Given this list of marker genes LSM4, APCDD1, SYT17, MYD88, ZBP1, WWOX, EDN1, RANBP3, SLAMF7, HSPB8 (NCBI Gene Id 8097), LY6G6D, SEC24B, EP400 (E1A binding protein p400), H1-4, EREG, TBC1D10B, SLC44A1, RMDN3, IFIT3, NDST2, PTMS, SLK, LPAR1, ARF5, DNAJC13, YTHDF1, PRDM1, TMEM192, UTRN, ACTB, CNIH2, KAT2B, PKIG, DNMT3A, TMBIM4, PDE1B, KRT85, HSPA2, TSPAN5, CASP4, MYBPH, SLC1A2, SPECC1 (NCBI Gene Id 92521), CUEDC1, BBS2, HTRA2, RNF214, UAP1, TAB3 (NCBI Gene Id 257397), MT4, SSR3, CAPN5, NIPAL2, CTNNA1 (catenin alpha 1), IL6, PRPF38A, KATNA1, GAS7, DDAH2, MAP4, AKT2, MAEA, GNG11, ARPP19, MRPS12, CABYR, PI4K2A, GABRA2, PARP14, STX1B, CA2, TXNDC17 (NCBI Gene Id 84817), UPP1, RCN2, PNRC1, NTS, CD180, XDH, TSPAN13, SLCO3A1, RIN1, MXI1, ITPK1, FKBPL, TMCO3, TPX2, SEC63, AZI2, LBH, DUSP16, RAB8B, APBB1IP, TIMELESS, PDGFRB, MYCN, TOMM70, CYP17A1, PKNOX2, IDNK, PTCRA, TUT7, KEAP1, TNXB, DAZ2, MAPK6, LONP2, LANCL2, WARS1, PHF21A, NCOA5 (nuclear receptor coactivator 5), SP6, HCN2, NDRG2, CASK, IFT81, PLEKHA2, IFI35, SHD, USP47, BOC, ABI3BP, ARHGAP23, EPHA6, WIPI1, SPHK2, PPM1B, IDH2, MRPS6, ATG4D, CCNE1, ZBTB11-AS1, CD300LF, BABAM1, ALDH1A2, NYNRIN, UFM1, NHERF1, ASB6, PI4K2B, NUDT19, BRAF, ARHGAP35, RLBP1, SKIL, CRIM1, SAT1, MAPK13, DEK, CISH, IGF2, SUV39H1, SLC22A9, SPTSSB, C5orf15, TAP2, RBL1, KMT2A, RPS6KA2, GPR155, CD274, PIP5K1A, CSF1, CTSC, NRDE2, WBP1L, BARX1 (BARX homeobox 1), POLB, ACP3, BMP2K, CFAP95, HRH3, MRPL54, CCL4, UFSP1 (NCBI Gene Id 402682), DNAJC2, CTCF, SNAPC2, REEP3, AP1G2, NCMAP, ANXA11, ANKIB1, SMC3, FRS3, DICER1, RAB3IP, TLR6, TMT1A, HELZ2, SLC32A1, UQCR11, VPS37B, NEFM, LRRK1, PCP4, CXCL10, GJC2, TULP1, APLP2, SEC23B, here is a description of the gene set: from publication Amit I, Garber M, Chevrier N, Leite AP, Donner Y, Eisenhaure T, Guttman M, Grenier JK, Li W, Zuk O, Schubert LA, Birditt B, Shay T, Goren A, Zhang X, Smith Z, Deering R, McDonald RC, Cabili M, Bernstein BE, Rinn JL, Meissner A, Root DE, Hacohen N, Regev A (PMID 19729616) Human Gene Set: GSE17721_LPS_VS_CPG_8H_BMDC_UP species: Homo sapiens Genes up-regulated in comparison of dendritic cells (DC) stimulated with LPS (TLR4 agonist) at 8 h versus DC cells stimulated with CpG DNA (TLR9 agonist) at 8 h. mouse primary BMDCs were stimulated with tlr ligands and gene expression changes were profiled on Affymetrix arrays